The following is a description of a gene set: Catalysis of the reaction: ATP + nucleoside diphosphate = ADP + nucleoside triphosphate. Mouse Gene Set: GOMF_NUCLEOSIDE_DIPHOSPHATE_KINASE_ACTIVITY studied in species Mus musculus, and this is the list of marker genes: Pck1, Nme5, Ak7, Nme3, Ak8 (NCBI Gene Id 68870), Nme1, Nme7, Nme4 (NCBI Gene Id 75413), Cmpk2, Ak1, Ak4, Nme6, Cmpk1, Ak5 (NCBI Gene Id 229949), Nme2, Dtymk, Ak9